The following is a description of a gene set: species: Mus musculus Intracellular mass of paired, helically wound protein filaments (also called PHF) lying in the cytoplasm of neuronal cell bodies and neuritic cell processes. Neurofibrillary tangles contain an abnormally phosphorylated form of a microtubule-associated protein, tau. The shape of these inclusions may resemble a flame or a star. Mouse Gene Set: GOCC_NEUROFIBRILLARY_TANGLE, and this is the list of marker genes: Mapt, Clu, Nefh, Nefm, Picalm